The following is a description of a gene set: studied in species Homo sapiens Genes negatively correlated with HAI response at 28d in peripheral blood mononuclear cell in adults (18-50) after exposure to Fluarix/Fluvirin, time point 7D. Comment: Supplementary Table 5: All genes whose expression (d3/d0 or d7/d0) correlates to the fold increase in HAI titers (d28/d0). Here we have used a systems biology approach to study innate and adaptive responses to vaccination against influenza in humans during three consecutive influenza seasons. We studied healthy adults vaccinated with trivalent inactivated influenza vaccine (TIV) or live attenuated influenza vaccine (LAIV). TIV induced higher antibody titers and more plasmablasts than LAIV did. In subjects vaccinated with TIV, early molecular signatures correlated with and could be used to accurately predict later antibody titers in two independent trials. Notably, expression of the kinase CaMKIV at day 3 was inversely correlated with later antibody titers. Vaccination of CaMKIV-deficient mice with TIV induced enhanced antigen-specific antibody titers, which demonstrated an unappreciated role for CaMKIV in the regulation of antibody responses. Thus, systems approaches can be used to predict immunogenicity and provide new mechanistic insights about vaccines. from publication Nakaya HI, Wrammert J, Lee EK, Racioppi L, Marie-Kunze S, Haining WN, Means AR, Kasturi SP, Khan N, Li GM, McCausland M, Kanchan V, Kokko KE, Li S, Elbein R, Mehta AK, Aderem A, Subbarao K, Ahmed R, Pulendran B (PMID 21743478) Human Gene Set: NAKAYA_PBMC_FLUARIX_FLUVIRIN_AGE_18_50YO_CORRELATED_WITH_HAI_28DY_RESPONSE_AT_7DY_NEGATIVE, and this is the list of marker genes: PPIA, ACBD6, SPTBN1, QRSL1, LRRC70, RGPD6, HECTD1, MAP3K2, STAG3L2, PSMB7, PRPF3, MSMO1, MS4A1, RAB11FIP2, ARPP19, RGPD2, TRAF3IP3, SRSF7, CLINT1, PIAS2, TM2D3, SSBP2, GON4L, PABPC1, MED17, GRAMD1B, NGDN, RICTOR, MED21, ARHGEF7, CREBZF, PIGA, ZNF655, GOLGA8B, VCPKMT, PDE7A, AIMP1, INPP5B, NR1D2, PPP1R2, USP48, PVALB, ZNF507 (NCBI Gene Id 22847), PPP4R3A, AIMP2, GPRASP1, KLHL28, LPP, TIGD1, GALNT3 (polypeptide N-acetylgalactosaminyltransferase 3), MAP3K1, AHCTF1, CYCS, SF1, JUND, PIK3R1, HINT1, ATF6B, GPS1 (G protein pathway suppressor 1), CD6, NRIP1, COX20, CCAR1, G3BP2, STAT4, SRSF5, TENT4B, TRAT1, HIPK1, TGFBR2, RNF138, RPL37, ELF1, PNO1, SFSWAP, SRSF3, LUZP1, RAP2A, PPP2R5C, PRP4K, MDM4, NSFL1C, ARID2, RAB5A (RAB5A, member RAS oncogene family), RIMKLB (ribosomal modification protein rimK like family member B), CTC1 (CST telomere replication complex component 1), FAM117B, MCOLN2, HERC2P3, KRR1, MSI2, ZNF430, IFT80, FAM85B, NOMO2, STAMBPL1, MED6 (NCBI Gene Id 10001), FAM153CP, PHF5A, SLC5A6, SIN3A, BAG4, ZFX, DHX40, UROS, P2RX4, CHD1, KPNA5 (NCBI Gene Id 3841), FBXL17, ATG14, BCLAF1, MKLN1, ITPKB, STAG3L1, RBBP6, PCYOX1L, IGF1R, TRAPPC10, ADAM28, OCLN, INPP5D, EML4, ZNF317, UBE2G2, NAP1L5, SAMHD1, FAM153A, DIS3L2, RANBP2, ANKZF1, BANK1, PHACTR2 (phosphatase and actin regulator 2), IPO11, BRD1, AFF3, METTL8, CFAP68, CD44, TRAF5, HNRNPM, ZFR, PLA2G12A, RBM8A, TESPA1, ATG13, GIGYF2, DNAJB1, ARF1 (NCBI Gene Id 375), SFI1, SSB, TAGAP, WDR75, LEF1, PTS, CXorf65, CCNL1, LRRFIP1, RGPD1, ZNF814, TNFRSF25, PSIP1, CHERP, IVD, CNOT4, ATP1B1, EHBP1, CEP95, NOMO3, KDM6A, RAB3IP, FAM98B, FNBP4, DHX30, MALAT1, ATP9B, EIF4A2, UNK, HBP1, NUP58, TWF1 (twinfilin actin binding protein 1), CSNK1A1, FAM120AOS, CWF19L2, RAB5B, MED1, SCAF4, RORA, ZEB1, CCDC66, YPEL5, CDC42, SNX9, PMAIP1, P2RY10 (NCBI Gene Id 27334), ZNF395, B4GALT1, GKAP1, PLXDC1, PTCD3, ARIH1, NUP54, KPNA4, SPOCK2, RBM34, RBM18, STAT5B, USF3 (NCBI Gene Id 205717), SLAMF1, SLC16A7, HNRNPL, GPR18, HLA-DQA1, ANKLE2, DHX9, CUL4B, YRDC, FHIT, SMG1, CALM1, RNMT, ECPAS, PHF3, ZNF274, JMY, RPRD1B, MPHOSPH9, PPP1R15A, TLE4, CLASP1, UBE2D3, NGRN, TSPYL1, TRMT13, POLR1F, ZNF195, HOXA7, SYS1, TOPORS, ASXL1, SBNO2, ENDOD1, PHKB (phosphorylase kinase regulatory subunit beta), DUSP4, SERPINF1, TGIF1, STRAP, AZI2, AFF4, SLC7A6, HEATR1, RHBDD1, NMT2, TRIB2, ASCC3, METTL3 (methyltransferase 3, N6-adenosine-methyltransferase complex catalytic subunit), PPM1A, IKBKE, TRA2B, CSRNP1, RGPD4, BBIP1, FUS, CDC42SE1, ATF2, MAP2K7 (NCBI Gene Id 5609), SMCR8, NKTR, POLR1C, SBDS, RGPD5, BOD1, HELQ, ZMYM5, BBX, CD96, FOXP1, RBM39, NR4A2, ZSWIM9, STK4, ANK3, RPS27, APOOL, JUN, KLF3-AS1, NUMA1, URI1, ATG16L1, C2orf49, CEP68, AP1G1, GFM1, HP1BP3, NT5E, IFNLR1, MIER3, DENND11, BLK, ZFP90, MED30, SINHCAF, DOCK9, ZNF202, SFXN3, E4F1, SUMO1, ATP11B, CAMK2G, GAS5, CTLA4, MED14, KLF9, TBC1D4, GOPC (golgi associated PDZ and coiled-coil motif containing), SPG7, PPM1K, FYTTD1, KLF3, CYB5R3, CAMK4, MBNL1, PHC3, CYLD, CCNT1, TAF15, SLC11A2, CTNNB1, DBR1, NUFIP2, ZNF12, TSPYL2, BCL11B, ZNF136, ANKRD44, THEMIS, LONP2 (NCBI Gene Id 83752), EHMT1, KLF12, CNOT6L, GATA3, RGCC, CLK1, PABIR3, SRSF6, PCBP2, C11orf58, CFAP20, RGS1, RGPD3, RFX7, DGKA, EPC1, FLT3LG, CDC5L, KLF6, NIBAN3, HNRNPA1, GNAS, SUGP2, H2BC8, FCRL1, PTK2, UBXN7, KCTD9, CBX5, DNAH1, MPZL3 (myelin protein zero like 3), FBXO28, STAP1, GTF3A (general transcription factor IIIA), METTL14 (NCBI Gene Id 57721), PIP4P1, NAA25, MTMR14, EZR, ZMYM2, ARMH1, ENOSF1, HECA, KLHL24, SUPV3L1, ATAD2B, RBM25, PDAP1, HELB, PIGL, SGTB, FGD3, DYRK2, PHF20L1, DYNC1LI2, STAG3L4, DUSP10, EIF1, ZBTB11, SEPTIN6, ZBTB21, YTHDC1 (YTH N6-methyladenosine RNA binding protein C1), PATJ (PATJ crumbs cell polarity complex component), ZNF318, OGT, GNE, SLC25A36, RAB8B, RPS6KB1, MYLIP, RUFY3, CD69, ATXN2L, IL6ST, ZNF451, RSRP1, NOMO1, PDP1, STAT3, AMD1, TNKS2, MBD4, LY9, LCOR, DCK, PSME4, PTP4A1, SLFN12 (schlafen family member 12), CCDC50, DLST, DDX3X, STK17A, FCRL2, TSC22D3, DDX24, CLEC2D, CCNYL1, GADD45GIP1, HPCAL1, TMED5 (transmembrane p24 trafficking protein 5), USP36, UXS1, UBE3A, VIRMA, HNRNPH1, RIF1, GOLGA8A, FBXO16, RAP2B, TMEM170A, BACH2, MIAT, NR4A3, KBTBD8, CD8B, TRPM7, TMEM63A, RGPD8, BAX, YTHDC2, PPFIBP1, PDXDC1, AKT3, UBE2B, RALGAPB, TFAM, EPG5, TCP11L2, RBM14, KAT6B, LINS1, UHMK1, ARL4C, INTS6L, RBM4, RBSN, SFPQ, ZBTB10